The following is a description of a gene set: Neighborhood of NF2 Human Gene Set: GCM_NF2 Neighborhood of NF2 neurofibromin 2 (bilateral acoustic neuroma) in the GCM expression compendium studied in species Homo sapiens, and this is the list of marker genes: DHRS11, ANKRA2, TUT1, MYO9A, RMND5B, TMEM199, MSL1, RAB14, METTL17, TBC1D15, ZNF644, KMT2A, HAPSTR1, TRAPPC14, SNAPC3, TNS2, GSPT1, RNF41, SLC35E2A, PRXL2A, LRIG2, KDM3B, VCF2, NAPG, C2CD5, RANBP6, NF2, SNRNP200, BRD9, RMDN3, TNPO1 (transportin 1), TSEN34, GFOD3P, WDR19, AP2A1, RAN, TNPO2, TBC1D22B, PRRC2B, RPS6KC1, AARS2, U2SURP, TSPYL4, SH2B1, BAHD1, COMMD9, ASH1L, TADA2B, BOD1L1, CNPPD1, RABGEF1, UPF3A, USP33, PHAX (phosphorylated adaptor for RNA export), VPS53, ACTR10, AAAS, DDX17, TMEM120A, POLDIP3, MTMR4, STRN4, XPO6, COG5, PJA2, ING1, DENND4A, ZBED1, FNTB, MKS1, EVI5L, MRPS5, SPTLC1, EDNRA, ARFGAP1, ISCA1, GMEB2, AFDN, GOLGA7, BCL2L1, ZNF710, MORF4L1, STAMBP, NUMA1, MTMR7, LEMD3, PSME3, ZDHHC4, SUMF2, DENR, RNF216, POGZ, YME1L1, PRKRA, CLEC16A, LUC7L2, SIN3A, RPL7L1, VRK3, ZNF84, SUV39H1 (SUV39H1 histone lysine methyltransferase), DDX47, TBCK, RABL2B, MEPCE, DCUN1D3, FN3KRP, UBE2N, POLR2M, ZXDB, MOB4, ANKRD10, GTF2A1, WBP2, KIAA1191, PPIG, MRPL10, PSME3IP1, BAZ2A, CSRNP2, MBD3, IPO5, ZER1, EHBP1, ASB3, ZNF12, H2AZ2, MAPK8IP3, NSUN5P1, ALKBH5, APPBP2, FOXO3, PREP, SAMD4B, NUCKS1, TM9SF3, RALGPS1, ASCC1, GATD3, KIAA2013, RTN4, FBXO9, ZFAND5, TSNAX (NCBI Gene Id 7257), RETREG2, JKAMP, MTRF1L, NCLN, TINF2, TBC1D10B, UBE2K, GPBP1, PIGS, AAR2, USP19, AMMECR1L (NCBI Gene Id 83607), SNX33, PATL1, SLC35B2, NPFF, HNRNPR, VCP, GLT8D1, FAM168B, LINC01278, CHAMP1, SPECC1L (NCBI Gene Id 8221), GGT7, CRAMP1, ZNF529, HAAO, KLHL12, DHCR7, WSB2, DYNC1I2, IRAG1, MRI1, MRPL30, OTUD6B, ERAL1, PACS2, SIDT2, ASB7, ENSG00000291228, TMEM138, ATG4B, IDH3G, NAA30, BPNT2 (3'(2'), 5'-bisphosphate nucleotidase 2), WDR70, FOXJ3, MAP6, COPS6, SLC38A7, MCRIP1, CHTOP, MAPK8IP1, PEX11B, OGFOD1, TMEM245, KLHL11, PHF10, FBXL20, PRPF8, KLF12, TRPC4AP, DHX37 (DEAH-box helicase 37), WDR33, RIPOR1, KLHL18, RIPK1, URGCP, APMAP, LIG3, ADPRS, VPS52, IQCK, GORASP1, MED17, TMEM106B, ERG28, SAFB, UBR7, B4GALT2, MMAB (NCBI Gene Id 89909), SETD1A, MTPN, OSBPL2, ATG2B, VPS26B, HECTD1, MFSD8, FAN1, ABHD16A, DBNL, EMC8, ATP2B2, ZNF559, INTS5, COQ10A, GFM2, CAND1, SCG2, SELENOI, RTBDN, CIZ1, C1orf52, CFAP298, HGS, TRAF7, PTCD3 (pentatricopeptide repeat domain 3), TTC17, ACAD11, DHX40, RIMOC1, PIP4K2B, CIAPIN1, PIP4P1, RAPGEF1, EIF4EBP2, TAF9B, MFN2, CHD9, WSB1, ZNF133, TBC1D14, EXOSC6 (NCBI Gene Id 118460), ZNF275, SEC22C, CS, UBQLN4, ANKRD40, TOX4, ZFR, BABAM1 (NCBI Gene Id 29086), AGAP4, KLHL17, ANAPC5, TEX261, WDR6, OCIAD1 (OCIA domain containing 1), KPNA6, NUP133, ASB6, RSC1A1, SCAMP2, TUBGCP4 (NCBI Gene Id 27229), EPS15L1, TMEM167B, CHUK, ZNF292, CENPO, MTCH2, IFT52, SAP130, ZNF512, PRDM4, SNX15, ATXN7L3, RABIF, VEZT, SMG5